Given this list of marker genes ROR1-AS1, TENT5A, AGTR2 (NCBI Gene Id 186), CRYM, COL4A6, NPNT, LY6H (lymphocyte antigen 6 family member H), NKD2, SERPINF1, CAVIN2, CFH, PLP2 (proteolipid protein 2), ASPN, TSPAN13, GPX3, MECOM, NTRK2, CXCL14, FGF7, TNC, HSD11B2, S100A4, DPT, NTF3, GALNT17, ALDH1A1 (NCBI Gene Id 96075), EFNB2, here is a description of the gene set: studied in species Homo sapiens Human Gene Set: HE_LIM_SUN_FETAL_LUNG_C0_AIRWAY_FIBROBLAST from publication He P, Lim K, Sun D, Pett JP, Jeng Q, Polanski K, Dong Z, Bolt L, Richardson L, Mamanova L, Dabrowska M, Wilbrey-Clark A, Madissoon E, Tuong ZK, Dann E, Suo C, Goh I, Yoshida M, Nikolić MZ, Janes SM, He X, Barker RA, Teichmann SA, Marioni JC, Meyer KB, Rawlins EL (PMID 36493756) Airway fibro